The following is a description of a gene set: Human Gene Set: HP_ABNORMAL_CIRCULATING_VITAMIN_B12_CONCENTRATION species: Homo sapiens Abnormal circulating vitamin B12 concentration A deviation from the normal concentration of cobalamin (vitamin B12) in the blood. Vitamin B12 is one of the eight B vitamins., and this is the list of marker genes: HLA-DQB1, GUCY2C, LMBRD1, CASP10, MMADHC, SLC19A1, MMAA, FAS, ABCD4, ABCD1, CBLIF, TCN2, RNF13, MMAB, MMACHC, MTR, FASLG, GRM7, MTHFD1, CUBN, AMN, MMUT, MTRR, PRDX1, HLA-DQA1